The following is a description of a gene set: from publication Edwards AD, Chaussabel D, Tomlinson S, Schulz O, Sher A, Reis e Sousa C (PMID 12816982) species: Homo sapiens The functional relationships and properties of different sub-types of dendritic cells (DC) remain largely undefined. We used a global gene profiling approach to determine gene expression patterns among murine splenic CD11c high DC subsets in an effort to better characterise these cells. Genes down-regulated in comparison of CD4 dendritic cells (DC) versus CD4- CD8- DCs. Human Gene Set: GSE339_CD4POS_VS_CD4CD8DN_DC_IN_CULTURE_DN, and this is the list of marker genes: TET1 (NCBI Gene Id 80312), CLDN7, TUBB6 (NCBI Gene Id 84617), PKD2, PGK2, SDSL, MACROD2, ERGIC3, GPX3, GLRB, MID1, TRPC5, TPRG1L, EIF4G1, PTPRG, RPE, CSNK2A2, ENG, C5orf15, GJC1, FOSL1, COX5A, SOX11, SMAP2, APAF1, MEIS2, PMPCA, PTPRN2, CAPNS1, SLC5A1, SCHIP1, CKMT2, NCOA1, HOXA11, PHOX2B, FGF3, PHC1, SFR1, RPAP1, GNAI1, ATP5PB, MYADM, EIF4ENIF1, KRT33B, SLC25A10, KCNJ12, ST6GALNAC1, SMYD5, SCEL, GABRB2, CUEDC1, LSR, PAPSS1, BAZ2A, RNF6, TUFM, DDX19A, TJP1, HNRNPUL2, SLC52A2, SELE, IL4R, SURF6, RAD1, AKR1B15 (NCBI Gene Id 442622), SLC7A8, DCC, ATP1B1, C1QTNF1, NKX3-2, CYB5B, PARN, ANKRD1, HNRNPR, KCNAB2, RNF34, APOA5, TM4SF5, MED12L, F2, PNN, RNF10, POSTN, PTGES, GP1BA, DOCK2, DCTN3, NTN1, CST3, MSH5, TCL1A, ATXN7L3, EIF4EBP2, FAM111A, YBX3, ARIH2, PPARD, TNFRSF21, CIB1, RARA, ZFP37, TACR2, CALCB, RPL28, CHL1, ANXA5, HOXA10, ACR, STK10 (serine/threonine kinase 10), GLI1, SLC12A5, ZIC4, SFRP1, IFNG, HGF, PPIB, AMOT, KIF16B, FMC1, ACKR1, ANXA10 (annexin A10), STAT3, ANKIB1, COL4A2, SLC35E4, KCNA2, C1QC, SMPD1, UXS1, RPL13A, IL2RB (NCBI Gene Id 3602), TMEM234 (transmembrane protein 234), RGS6, TUBG2, MPV17, B3GALT1, FABP9, COL6A2, PDAP1, ANLN, KCNH2, TRAIP (TRAF interacting protein), HOMER3 (homer scaffold protein 3), RPL23A, FRAT1, BMP8B, ERF, RNF138, DMGDH, RHOQ, IYD, SP1, ARX, MRC1, DDT, NPNT, UROD, RRM2, PRKD2, HAGH, MYCBP, MBP, TNFRSF19, UMOD, TARBP2, ISCA2, MID1IP1, ESYT1, OR2H1, KANK3, MAN1B1, NUDT1, CAV3, HESX1, GPSM3, AP1M1, FCGR2B, CCL1, MPRIP, REEP6, TSKU, TRIM28, GFER, PBRM1, LIPC (NCBI Gene Id 3990), BSCL2 (NCBI Gene Id 84753), APBB2, HNRNPK, ACAA2, DHRS4, TNNI2, AP2A2, ALPG, WNT11, ASIC5, TRIM41, POLR2L, GUSB, IL13RA2, CENPK